The following is a description of a gene set: species: Mus musculus Nuclear Events (kinase and transcription factor activation) Mouse Gene Set: REACTOME_NUCLEAR_EVENTS_KINASE_AND_TRANSCRIPTION_FACTOR_ACTIVATION, and this is the list of marker genes: Mapk3, Ppp2cb, Ppp2r1a, Srf, Dusp3, Mapkapk2, Mapk1, Sgk1, Nab2, Rps6ka1, Creb1, Vrk3, Mapk11, Chd4, Dusp7 (dual specificity phosphatase 7), Rps6ka5, Egr2, Rps6ka2, Ppp2r1b, Mapk7, Ppp2ca, Dusp4, Rps6ka3, Dusp6, Mapk14, Atf1, Ppp2r5d